Given this list of marker genes Cmpk2, Isg15, Zbp1, Helz2, Iigp1, Ifit3b, Grn, Ifit1, Irf7, Stx7, Rtp4, Gbp2, Gbp7, Daxx, Slfn2, Isg20, Usp18, Ifitm3, Cd86, Setdb2, Ddx60, Psmb8, H2ax, Ifit2, Aida, Clic4, Plaat3, Trim30a, Pnp, Trafd1, Ifi35, Phf11b, Herc6 (NCBI Gene Id 74620), Pim1, Ube2l6, Cxcl10, Lgals3bp, Samd9l, Macir, Rsad2, Ifi211, Mcpt8, Oas3, Smg1, Epsti1, Mx1, Cd274, Oas2, Stat1, Oasl2, Gadd45g, Ifi47, Gbp5 (guanylate binding protein 5), Lgals9, Ifi208, Slfn5, Ifi207, Ifit3, Ifih1, Bst2, Trim30c (tripartite motif-containing 30C), Mitd1, Trim30d, Samhd1 (SAM domain and HD domain, 1), Ly6a, Uba1, Rigi, here is a description of the gene set: studied in species Mus musculus Genes positively differentially expressed in cell type: Mast cell upon treatment with cytokine: IFN-β in mouse lymph nodes in vivo. Mouse Gene Set: CUI_MAST_CELL_IFNB_RESPONSE_UP Cytokines mediate cell-cell communication in the immune system and represent important therapeutic targets. A myriad of studies have highlighted their central role in immune function, yet we lack a global view of the cellular responses of each immune cell type to each cytokine. To address this gap, the authors created the Immune Dictionary, a compendium of single-cell transcriptomic profiles of more than 17 immune cell types in response to each of 86 cytokines (>1,400 cytokine-cell type combinations) in mouse lymph nodes in vivo. A cytokine-centric view of the dictionary revealed that most cytokines induce highly cell-type-specific responses. For example, the inflammatory cytokine interleukin-1β induces distinct gene programmes in almost every cell type. A cell-type-centric view of the dictionary identified more than 66 cytokine-driven cellular polarization states across immune cell types, including previously uncharacterized states such as an interleukin-18-induced polyfunctional natural killer cell state. from publication Cui A, Huang T, Li S, Ma A, Pérez JL, Sander C, Keskin DB, Wu CJ, Fraenkel E, Hacohen N (PMID 38057668)